Given this list of marker genes Casp9, Trp53, Dll1, Mapk8, Prkch, Rad21, Enpp1, Gas6, Prkci, Akap12, Traf2, Igf1, Tnfrsf21, Prkca, Rb1, Cers6, Casp3, Pmp22, Prkcd, Ccl12, Cdk5, Trem2, here is a description of the gene set: Mouse Gene Set: GOBP_GLIAL_CELL_APOPTOTIC_PROCESS Any apoptotic process in a glial cell, a non-neuronal cell of the nervous system. studied in species Mus musculus